Given this list of marker genes Esrrb, Adcy8, Hint1, Atp5f1d, Ak3, Abcc9, Dmac2l, Adsl, Nppc, Adcy1, Umps, Ep300, Bend3, Atp6-ps, Mfn1, Sult2a4, P2rx7, Adpgk, Ndufs4, Eno2, Gapdhrt, Dhtkd1, Atp5if1, Ndufv3, Myc, Aldoart1, Slc25a13, Zbtb7a (NCBI Gene Id 71606), Tmsb4x, Impdh2-ps, Rfk, Bloc1s6, Npr1, Pde5a, Pgk1, Gmps, Gart, Bcl2l1 (NCBI Gene Id 12048), Eno4, Il3, Adss2, Hk1, Xdh, Sult2a1, Nt5c, Prkaa1, Ndufs6, Sult1e1, Pde10a, Fbp1, Tpi1, Nme6, Map2k1, Uprt, Stoml2, Mfsd8, Nudt5, Nme4, Pfkm, Adcy2, Atp5pd, Pklr, Sult1b1, Nme1, Tgfb1, Myh6, Atp2b2, Slc2a6, Ddit4, Pygl, Insr (NCBI Gene Id 319666), Parp1, Nudt10, Sult2a7, App, Hspa8, Src, Ak1, Pde1a, Ppp2ca, Guk1, Ndufb6, Pkm, Upp2, Myh3, Fkrp, Prxl2c, Pid1, Atp5mc3, Ctps1, Hprt1, Ada, Git1, Nme3, Ndufs1, Ndufb7, Entpd5, Uox, Ampd3, Dhodh, Ifng, Ndufs2, Nme5, Vcp, Aprt, Nmnat1, Urad, Atp6v1b1, Ndufa2 (NCBI Gene Id 17991), Prps1l1, Ndufv1 (NCBI Gene Id 225885), Trex1, Adcy6, Ndufb1, Atp5pf, Mlxipl, Sirt6, Ndufs8, Ndufa6, Atp1b1, Mtch2, Nudt18, Ppargc1a, Hspa1b, Cmpk1, Sult2b1, mt-Nd5, Gucy2c, Pals1, Adcy4, Sult1c1 (sulfotransferase family, cytosolic, 1C, member 1), Flcn, Atp5po, Ndufb2, Ppat, Clpx, Efl1, Adcy7 (NCBI Gene Id 11513), Rnaseh2b, Actn3, Impdh2 (inosine monophosphate dehydrogenase 2), Uckl1, Slc25a25, Dnm1l, Slc4a1, Gmpr2, Upb1, Ndufb9, Entpd7, Uchl1, Entpd4b, Prkag1, Mthfd1, Prpsap1, Pgam1, Ctps2, Bad, mt-Nd6, Ndufa7, Uck1 (NCBI Gene Id 22245), Nudt14, Mlx, Ndufa1, Atp5f1e, Ndufa11, Ogdh, Nt5c2, mt-Atp8, Prps2, Adcy9, Sphk2, Sdhb, Atp5pb, Mpi, Adcy10, Mlst8, Ndufc1, Papss1, Aldoart2, Ak9, Atp6v1a, Arl2, Nme2, Ier3, Adcy3, Pgk2, Eno1, Ndufab1, Nudt2, Foxk2, Htr2a, Pde8a (phosphodiesterase 8A), mt-Nd4, Sult2a2, Psen1, Rora, Atp5mf, Cfh, Sult2a8 (sulfotransferase family 2A, dehydroepiandrosterone (DHEA)-preferring, member 8), Sdha, Ndufb8, Gucy2d, Ctns (cystinosis, nephropathic), mt-Nd2, Pde9a, Gapdhrt2, Gnai3, G6pd2, Igf1, Aldoc, Rhoa, Gapdhs, Atp5f1a, Il4 (NCBI Gene Id 16189), Itpa, Ndufb3, Ndufb10, Nt5c1a, mt-Nd3, Sdhd, Prkag2, Gucy2f, Ndufs3, Bpgm, Hrh3, Nme7, Ndufb5, Nppb, Nt5c1b, Nudt4, Ak4, Pals2, Eno3, Prkn, mt-Atp6, Ndufa13, Trem2, Slc4a4, Prkag3, Stat3, Myh8, Gucy2e (NCBI Gene Id 503686), Uqcc3, Atp1a2, Galk1, Ndufv2, Fis1, Tkfc, Papss2, Ndufa10, Tigar, Foxk1, Gucy2g (guanylate cyclase 2g), Ndufa3, Pth2, Ndufs5, Pfas, Prpsap2, Zbtb20, Prps1, Ppara, Ndufa5, Paics, Rhoq, Sik2, Pde7a, Atp5mc1, Prkaa2, Cda, Pfkfb1, Dnajc30, Atg5lrt, Fignl1, Atp7a, Myh7, Cacnb4, Cad, mt-Nd4l, Ndufc2, Gapdh, Antkmt, Ogt, Atp5me, Enpp1, Rab23, Hnf1a, Ola1, Pde8b, Gale, Gimap7, Adss1, Pfkl, Myog, Slc25a12, Ndufb4, Atp6v1b2, mt-Nd1, Entpd4, Eif6, Ndufa12, Selenon, Dck, Fam3a, Enpp3, Ins2, Trim63, Prps1l3, Uck2, Adk, Pgam2, Ampd2, Bcl2l13, Opa1, Gucy1a1, Atp5f1b, Cox11, Nupr1, Nudt3, Lrrk2, Ampd1, Atp5mg, Galt, Rptor, Ucp2, Hkdc1, Impdh1 (inosine monophosphate dehydrogenase 1), Atp5mc2, Aldoa, Aldob, Ndufs7, Letmd1, Ins1, Pfkp, Npr2, Ndufb11, Arnt, Sult2a5 (NCBI Gene Id 434264), Lipa, Col6a1, Nppa, Dpys, Abcc6, Gpi1, Adcy5, Cbfa2t3, Ak2, Pde4c, Atp5f1c, Gtpbp1, Nt5c3, Atic, Pde2a, Kat2b, Nudt9, Gpd1, Sult2a6, Ran, Hk3, Pnp, Sult2a3, Tspo, Hk2, Nt5e, Ndufa8, Prkaca, Upp1, Sdhc, Khk (NCBI Gene Id 16548), Parg, Dpyd, Ldhd, Pfkfb3, Slc29a1, Atpsckmt, Hif1a, Gucy1b1, Gda, Pfkfb2, Entpd1, Ndufa9, Pde4a, Ncor1, Jmjd8 (NCBI Gene Id 72106), Nudt11, Hdac4, Ak5, G6pdx, Pde7b, Pde4d, Gck, Urah, Gmpr, Ldhc, Epha2, Eno1b, Mtor, here is a description of the gene set: studied in species Mus musculus Mouse Gene Set: GOBP_RIBOSE_PHOSPHATE_METABOLIC_PROCESS The chemical reactions and pathways involving ribose phosphate, any phosphorylated ribose sugar.